The following is a description of a gene set: species: Mus musculus Mouse Gene Set: REACTOME_DAP12_INTERACTIONS DAP12 interactions, and this is the list of marker genes: H2-Q7, Clec5a, Rac1, Trem1, Klrc1, H2-M5, H2-M10.4, Syk, H2-M10.3, H2-M3, Hras, H2-M10.2, H2-M10.1, Plcg1, H2-M2, H2-Q2, Klrc3, Vav3, Fyn, H2-M1, Vav2, Klrk1, H2-M9, Lck, Kir3dl1, Trem2, H2-M10.5, Siglecg, Sos1, Cd300e, Tyrobp, Klrc2, Gm5150, H2-Q4, Pik3r2, Kir3dl2, Klrd1, Btk, Pik3r1, H2-T10, H2-T22, Siglec15 (sialic acid binding Ig-like lectin 15), Grb2 (growth factor receptor bound protein 2), Cd300lb (NCBI Gene Id 217304), Plcg2, Lat, H2-Q1, H2-Q6, Pik3cb, H2-Q10, Shc1, H2-K1, Lcp2, Grap2, B2m, H2-M11, H2-M10.6, H2-T23, Pik3ca, Kras